The following is a description of a gene set: studied in species Mus musculus Genes predicted to be targets of miRBase v22 microRNA mmu_miR_493_5p in miRDB v6.0 with MirTarget v4 prediction scores > 80 (high confidence targets). Mouse Gene Set: MIR_493_5P from publication Chen Y, Wang X (PMID 31504780), and this is the list of marker genes: Ppargc1a, Mllt10, Bbx, Dll1, Cenpc1, Tmeff1, Zdhhc17 (NCBI Gene Id 320150), Axin1, Tmem106b, Ccdc167, Srpk2, Slc26a3, Slitrk6, Hipk1, Setdb2, Scaf11, Map3k12, Plpp1, Sat1, Rab5c, Tex30, Srpx, Gsx1, Ppp2r2c, Myt1l, Sp1, Cspp1, Lman1, Hivep2, Fgd4, Arfgef1, Erg, Kalrn, Zfand5, Grm5, Rbm34, Dach1, Ak5, Gabra5, Cxcl2, Tnrc6a, Snrpb2, Lrig1, Mbd5, Fgf15, Pbx3, Pwwp3b, C1ql1, Sufu, Ppp2r5d, Kif27, Asb15, Hmgn1, Bcl7a, Bcor, Pcdhb12, Sh2d3c, Mrpl1, Sh2b3, Antxr1, Denr, Slc15a2 (solute carrier family 15 (H+/peptide transporter), member 2), Mapk8, Bnc1, Stag1, Hspa12a, Dlg2, Klrb1f, Irx2, Tacc1, Ska2, Eif4enif1, Wdr33, Fermt2, Vamp2 (NCBI Gene Id 22318), Togaram1, Fubp1, Etv5, Hs3st3b1, Cdh13, Trim2, Pank3, Scn1a, Kdelr2, Kcns3, Crispld2, Tubgcp5, Pik3r1, Sall1, Slain2 (SLAIN motif family, member 2), Gdnf, Pdc, Dcun1d1, Tsc22d2, Mef2a, Ythdf3, Epha7, Thbs1, Gypa, Mef2c, Faxc, Nectin3, Vps54, Cyth3, Tmem170b, Cog3, Tab3, Mgat3, Kdm6a, Tubgcp4, 9530068E07Rik, Fbrsl1, Gsdmd, Ccdc30, Rasal2, Ankrd17, Adam23, Cadm2, Ccdc138, Zfp384, Lonrf1, Sertad2, Tgfbrap1, Pou4f1, Usp32, Syt4, Wnt5a, Mbnl2, Cited2, Slc34a2, Oip5, Ms4a4c, Zfhx3, Ctdspl2, Pkib, Apoo, Pcm1, F8a, Rab5a, Nqo2, Casp8ap2, Kcnj6, Nedd4l, Gpr63, Gtf3c3, Jazf1, Dip2c, Zbtb33, Dld, Tdo2, Ahdc1, Nudt4, Neo1 (neogenin), Fam24b, Jun, Atad2, Rreb1, Nlgn3, Ube2g1, Sp3, Tsg101, Nfkbia, Plcb1, Klf3, Kpna4 (NCBI Gene Id 78766), Pard6b (par-6 family cell polarity regulator beta), Ubtfl1, Npas3, Mllt3, Brd10, Rfx7, Steap2, Ints8, Otud1, Lrp12, Barhl2 (BarH like homeobox 2), Nrde2, Daam1, Shisa3, Elovl5, Zfp518a, Pdpk1, Stt3b, Mtus1, Wnt5b, Rhot1, Ano4, Pag1, Rab18, Susd6, Kcna2, Dach2, Hook3, Phf20l1, Ube3d, Exosc1, Tial1, Gabra6, Dip2a, Pcgf2, Atp2a2, Gabpb2, Ube2v2, Abca5, Sptbn1, Med13l, Cxadr, Alg14, Basp1, Fmnl2, Phactr4, Nav2, Cdh2, Limch1, Lrrc8c, Rasl11b, Fbln1, Ppm1e, Nbea, Esx1, Gad1, Carm1, Adi1, Rin2, B3gat2, Unc50, Sbno1, Dyrk4, Chd9, Dgkd, Ankrd50, Zfp638, Dab2ip, Daam2, Pum2, Sgk1, Atp5mk, Map1b, Dennd4c, Svep1, Zic2, Zfp318, Sin3a, Brd8, Fhod3, Rapgef2, Cts8, Hibch, Itgam, Lrp11, Tnrc6b, Gabrg2, Ap3s1, Arhgap44, Atad2b, Rab3c, Memo1, Scn2a, Tspoap1, Scyl1, Vps13d, Lrguk, Slc10a7, Rab10, Ms4a4d, Megf11, Fnip1, Smap1, Faim, Dusp16, Ttn, Itgb1, Nxph2, Ppp1cc, Thsd7a, M6pr, Pitpnb, Tmx1, Cdh11, Gm8369, Paip1, Fbxl22, Spin4, Brd7, Dab1, Ovol1, Osbpl6, Rev3l, Gria3, Eomes, Cmbl, Tbc1d22b, Spon1, Col11a1 (collagen, type XI, alpha 1), Hecw2, Svip, Mfsd14a, Hdgfl3, Endod1, Ttc7b, Trp63, Serinc1, Rbl1, Ms4a4b, Pmp22, Gtf2ird1, Nek4, Scamp5, Dhx36, Abtb2 (ankyrin repeat and BTB domain containing 2), Sorcs3, Agtr1a, Tbc1d4, Foxo1 (NCBI Gene Id 99758), Gon4l, Pes1, Smg1, Trhde, Vash2, Ltbp3, Mtmr10, Map3k2